Given this list of marker genes HSD3B2, TERT (NCBI Gene Id 7015), ZNRF3, PRKAR1A, CTNNB1, TP53, POR, NR3C1, CYP11B1, CDKN2A, WNT4, here is a description of the gene set: Abnormal circulating androstenedione concentration Any deviation from the normal concentration of androstenedione in the blood circulation. Human Gene Set: HP_ABNORMAL_CIRCULATING_ANDROSTENEDIONE_CONCENTRATION studied in species Homo sapiens